The following is a description of a gene set: This event has been computationally inferred from an event that has been demonstrated in another species.<p>The inference is based on the homology mapping from PANTHER. Briefly, reactions for which all involved PhysicalEntities (in input, output and catalyst) have a mapped orthologue/paralogue (for complexes at least 75% of components must have a mapping) are inferred to the other species. Reactome Pathway: Scavenging by Class B Receptors species: Mus musculus part of: Binding and Uptake of Ligands by Scavenger Receptors electronically inferred by orthology from the curated human pathway, and this is the list of marker genes: Apoa1, Prdx1, Cd36, Apob, Hmgb1